The following is a description of a gene set: Human Gene Set: GOBP_COLUMNAR_CUBOIDAL_EPITHELIAL_CELL_DEVELOPMENT species: Homo sapiens The process whose specific outcome is the progression of a columnar/cuboidal epithelial cell over time, from its formation to the mature structure. A columnar/cuboidal epithelial cell is a cell usually found in a two dimensional sheet with a free surface. Columnar/cuboidal epithelial cells take on the shape of a column or cube., and this is the list of marker genes: GATA2, ROS1, TIGAR, RARB, RARA, KLF5, XBP1, NKX3-2, BHLHA15, HIF1A, PGR, IL6ST (NCBI Gene Id 3572), YIPF6, TLR9, SRC, HOXA5, TMIGD1, RARG, GPAT4, YAP1, SLC9A4, TGFB1, FZD5, MIR29B1, SPDEF, C1GALT1, PRDM1